Given this list of marker genes RBFOX1, EIF4E, MTSS1, CLCN3, SMIM36, STK39, HSPD1, here is a description of the gene set: Human Gene Set: IKEDA_MIR1_TARGETS_DN Calcium signaling is a central regulator of cardiomyocyte growth and function. Calmodulin is a critical mediator of calcium signals. Because the amount of calmodulin within cardiomyocytes is limiting, the precise control of calmodulin expression is important for the regulation of calcium signaling. In this study, we show for the first time that calmodulin levels are regulated posttranscriptionally in heart failure. The cardiomyocyte-restricted microRNA miR-1 inhibited the translation of calmodulin-encoding mRNAs via highly conserved target sites within their 3' untranslated regions. In keeping with its effect on calmodulin expression, miR-1 downregulated calcium-calmodulin signaling through calcineurin to NFAT. miR-1 also negatively regulated the expression of Mef2a and Gata4, key transcription factors that mediate calcium-dependent changes in gene expression. Consistent with the downregulation of these hypertrophy-associated genes, miR-1 attenuated cardiomyocyte hypertrophy in cultured neonatal rat cardiomyocytes and in the intact adult heart. Our data indicate that miR-1 regulates cardiomyocyte growth responses by negatively regulating the calcium signaling components calmodulin, Mef2a, and Gata4. from publication Ikeda S, He A, Kong SW, Lu J, Bejar R, Bodyak N, Lee KH, Ma Q, Kang PM, Golub TR, Pu WT (PMID 19188439) studied in species Mus musculus Genes down-regulated in hypertrophic hearts (due to expression of constitutively active form of PPP3CA) and predicted to be targets of miR-1 microRNA.